The following is a description of a gene set: species: Homo sapiens Human Gene Set: GOBP_INFLAMMASOME_MEDIATED_SIGNALING_PATHWAY An intracellular signal transduction pathway that starts with a ligand binding to a pattern recognition receptor (PRR), assembly of the inflammasome complex, leading to the activation of CASP1 and inducing an inflammatory response. In some cases, inflammasome-mediated signal transduction can lead to programmed cell death, such as pyroptosis., and this is the list of marker genes: TRIM65, TLR4 (toll like receptor 4), FBXL2 (NCBI Gene Id 26008), IRGM, TLR6, SIRT2, CD36, ABHD17A, PYCARD, GBP2, CPTP, PYDC2, DDX3X, PRKD1, CARD8, DHX33, NLRP1, LAMP2, NEK7, PYDC1, ELP6, TREM2, MAPK8, BTK (NCBI Gene Id 695), STMP1, LATS1, NLRC3, KCNJ8, HSPA8, CSNK1A1, ZDHHC5, PYDC5, NLRP2B, MARCHF5, PTPN22, OGT, IFI16, MEFV, ZDHHC1, NLRP6, LATS2, GBP5, TRIM31, GKN2, P2RX7, KCNK6, PLCG2, KCNK13, ATAT1, MAVS, NLRP3, ZDHHC12, MYD88, TRIM11, PPP2CA, BRCC3, USP50, MARK4 (NCBI Gene Id 57787), ABHD8, EIF2AK2